Given this list of marker genes Tox3 (TOX high mobility group box family member 3), Ankrd44, Trp53inp2, Wdr93, Prdm1, Gabrb3, Ankle1, Them4, Dscam, Pgm1, Tram1, Slc8a3, Mbtps2, Myot, Pappa, Trim33, Bbx, Ptf1a, Sema3g, Map3k9, Luzp1, Dlg2, Pde3b, Eny2, Dyrk1a, Tnfaip8l1, Pym1, Cops7b, Zzef1, Bltp3a, Mapk8, Wdfy3, Ntaq1, Mospd1, Nckap5, Pgap2, Ppl, Tmem170b, Slc17a1, Krt35, Sema6d, here is a description of the gene set: from publication Chen Y, Wang X (PMID 31504780) studied in species Mus musculus Mouse Gene Set: MIR_7687_3P Genes predicted to be targets of miRBase v22 microRNA mmu_miR_7687_3p in miRDB v6.0 with MirTarget v4 prediction scores > 80 (high confidence targets).